Given this list of marker genes PDPK1, PIK3CA, PIK3R1, SHC1 (SHC adaptor protein 1), NCK1, EXOC3, INS, AKT1, EXOC6, PARD6A, EXOC5, GRB2, PTPRA, EXOC4, CAV1, CBL, DOK1, HRAS, EXOC7, SGK1, TRIP10, RAPGEF1, GRB10, EXOC1, F2RL2, PTPN11, FOXO3, NCK2, RPS6KB1, SORBS1, IRS1, SH2B2, PRKCI, RHOQ, SOS1, AKT2, PTPN1, CRK, INSR, PRKCZ, RASA1, GRB14, EIF4EBP1, EXOC2, here is a description of the gene set: Insulin Pathway studied in species Homo sapiens from publication Schaefer CF, Anthony K, Krupa S, Buchoff J, Day M, Hannay T, Buetow KH (PMID 18832364) Human Gene Set: PID_INSULIN_PATHWAY